The following is a description of a gene set: studied in species Mus musculus from publication Yevshin I, Sharipov R, Kolmykov S, Kondrakhin Y, Kolpakov F (PMID 30445619) Mouse Gene Set: UBN2_TARGET_GENES Genes containing one or more binding sites for (Ubn2) in their promoter regions (TSS -1000,+100 bp) as identified by GTRD version 20.06 ChIP-seq harmonization., and this is the list of marker genes: Sharpin, Fchsd1, Mpnd, Gm38411, Gm23991, Nrarp, Gm15564, Safb, Gm14401, Pepd, Evx1os, Celf5, Cnih2, Efcab2, Gm37450, Kif5a, Mllt10, Tsg101, Cebpb, Gm13135, Igsf3, Kif26a, Crb3, Paip2b, Tstd2, Atp6v1g2, Syngr3, Gm21411, Pms2 (NCBI Gene Id 18861), Msc, Ino80d, Zfp981, Smarca5, Gm43380 (predicted gene 43380), Smpd1, Cd248, Kctd6, H2bc6, Map4k4, Helz, Mettl25b, Hsp90ab1, Mtss1 (NCBI Gene Id 70087), Cfap97d1, Stx16, Serpinb6c, Hic1, Apoc4, Coq5, Gpr19, Catsper2, Dnal1, Prpf38a, Mark1, Clec2l, Ganab, Tspyl3, Rbm25, Dennd1b, Rab14, Dnajb11, Zfp936, Gpr84, Sec16b, Tmem267, Epb41l5, BC018473, Bmp4, Mapk3 (mitogen-activated protein kinase 3), 4930520M14Rik, Mir3473c, Dnah2, Katnbl1, Nudc, Raet1d, Fryl, Mrpl24, Scamp3, Trip12, Vezf1, Sctr, Sgk2, Snord57, Myo1g, Chd5, Tmcc3, 5031439G07Rik, 3110070M22Rik, Gm11399, Zfp106, Rere, Zfp998, Atp5f1b, Metap2, Speer4cos, Dnaja1, Kat14, Tmem88b, Zfp30, Ndufs5 (NCBI Gene Id 595136), Tomm5, Snord34, Ciapin1, Prim2, Gm21978, Zfp771, Stk4, E130215H24Rik, Dusp3, Coq8b, Phf21a, Vars2, Trim66, Ino80dos, Fjx1, Bricd5, Mat2b, Nfyb, Mcc, Sult5a1, Gm5067, Zfp667, Traf5, Itpa-ps2, Rilpl1 (NCBI Gene Id 76185), Frmpd1, Rasa2, Pcsk2, Dcaf5, Ppfibp2, Cmtr2, Snapc5, Ndel1, Btbd9, B3gnt5, Arhgap23, Stat5a, Sec24d, Gsta2, Tox2 (TOX high mobility group box family member 2), Srp72, Pgls, Rgs8, Rnf227, Sec61a2, Rnf182, Cct6a, Rars1, Gsta3, Llgl1, Pebp1, 1110059E24Rik, Ckap4, Iqce, Gm8357, Mir207, Idh3b, Cspp1, Npr1, Wiz, Pi4k2a, Gm16096, Sec23a, Rhobtb1, Kdm2b, Abhd17b, Tsr1, Gm22973, Gm33533 (predicted gene, 33533), Sptbn2, Tmprss5, Agtrap (angiotensin II, type I receptor-associated protein), Znhit3, Gtf2ird1, Usp16, Grb7, Phaf1, Apoc2, Ccdc116, Tmcc1, Phf10, Ydjc, Gm11398, Chat, Septin9 (septin 9), Ppp4r4, Csde1, Tmem250, Gm13034, Tnnt1 (NCBI Gene Id 21955, troponin T1, skeletal, slow), Snora15, Inpp1, Cabp1, Ppp1r1a, Unc119b, Rnf225, Duxf1, Spata31e2, Or6s1, Mpzl1, Hba-x, Wnt4, Shisa5, Cobl, Gm17149, Doc2b, Zpld2, Wnt5b, Dner, Mga, Nme7, Pde7b, Abcg2, Rnf2, Dlg1, 1700067K01Rik, Tarbp1, Nrcam, Zfp236, A230083N12Rik, Tmem230, Zfp638, Rorc, Nherf2, Rpl10-ps6, Tada1, Shank1, Cibar1, Acat2, Mir6347, Speg, Bcl2l12, Ube2e1, Fam43b, 1700025G04Rik (RIKEN cDNA 1700025G04 gene), Ralgps1, Cables1, Psma6, Tap1, Cds2, Zfp825, H2-K2, Col18a1, Gm15247, Irf3, Cep63, Rnu1b2, Cog4, Gm15471, Mir1966, Gm5069, Kras, Lrrc8c, Tex54, Cdc5l, Ptp4a1, Gm8815 (predicted gene 8815), Carf, Ttc9b, Gm4349, Mterf2, Ppp2r2a (protein phosphatase 2, regulatory subunit B, alpha), Klf12, Gm13431, Sfi1, Eif3f, Agpat3, Glrx3, Rnf157, Mbd6, Onecut3, Slc5a11, Lpgat1, Mmel1, Hsd17b8, Pdpk1, Zfp874a, Khdc4, Entpd3, Pnisr, Slc7a1 (NCBI Gene Id 264068), Mettl17, Paip1, Mir5128, Cenph, Srrt, Irf5, Trpc4ap, Slc25a20, Morc3 (NCBI Gene Id 93946), Bcl2, Cyp20a1, Cyp4f13, Ifrd1, Slc29a4, Col26a1, Ndufb10, Zfp988, Slc11a1, Coil, Slco5a1, Arhgef2, Vps29, Cse1l, 2700049A03Rik, Platr30, Aanat, Cdk17 (cyclin dependent kinase 17), Rgs12, Prmt5, Ifrd2, Snord35a, Trmt13